The following is a description of a gene set: Abnormal umbilicus morphology studied in species Homo sapiens An abnormality of the structure or appearance of the umbilicus. Human Gene Set: HP_ABNORMAL_UMBILICUS_MORPHOLOGY, and this is the list of marker genes: HSPG2, ANTXR1, FRAS1, IRF6, EIF4H, FTO, MBTPS2 (NCBI Gene Id 51360), ZMPSTE24, MYH3, ROR2, MID1, LMOD1, HESX1, FKBP14 (NCBI Gene Id 55033), POLR3GL, SCN2A, EHMT1, GPC4 (glypican 4), ERCC3, FANCL, MLXIPL, TARS1 (NCBI Gene Id 94887), NOTCH1, TFE3 (transcription factor binding to IGHM enhancer 3), FZD2, NSD1, FANCA, PHGDH, PNKP, UFD1, KNSTRN, GTF2IRD2, SLC2A10, LHX4, AGPAT2, SLC5A5, PORCN, NAA10, SLC32A1 (solute carrier family 32 member 1), ABCC8, TRIP11, FANCE, PRDM5, TRPV6, LRP2, NEUROD2, GTF2IRD1, AUTS2, GZF1, TOR1A, BRIP1, NKX2-1, NOTCH2, AARS1, EZH2, COL5A1, SLC25A22, RFC2, TGFBR2, CAVIN1, PLAGL1, FANCM, FREM2, DMXL2, PRR12, CHRNG, C1R, EFNB1, KMT2C, SRCAP, IDUA, FANCD2, LBR, GPHN, FBLN5, CLIP2, NFIX, MEG3, GJA1, DVL1, BSCL2, MYLK, FOCAD, PIK3CD (NCBI Gene Id 5293), ATP6V0A2 (ATPase H+ transporting V0 subunit a2), MSX1, GMNN, BUD23, ATAD1, RREB1, RFWD3, DNMT3A, MED13L, STX1A, CDKL5, KCNJ11, ACTG2, KCNA1, EOGT (NCBI Gene Id 79580), MED12, KRT1, LONP1 (lon peptidase 1, mitochondrial), ADAMTS2, ARVCF, GRM7, SH3PXD2B, ERCC2, GRIP1, RNF113A, GPC6, NXN, SLC26A2, SGSH, MYH11, CAPRIN1, SLC25A24, FGD1, NSDHL, KIF7, ADNP, PIGL, ELN, RAB23, HYMAI, GUSB, ARX, MESP2, ZBTB24, MAPRE2, DUOX2, GLI3, LTBP4, BCL11B, MAN2B1, DGCR8, MTOR, SLC35C1, DLL3, IYD, COX11, SUZ12, TP63, NKX2-5, SIK1, METTL27, RTL1, GRIN1, GTF2I, GATA6, SALL1, BAZ1B, PIGQ, PPP2CA, TBX1 (T-box transcription factor 1), FANCB, SPECC1L, CLDN19, DNMT3B, ATRX, KCNH1, CDCA7, OCLN, FOXE1, ABCC9, APC2, SLC6A5, SNIP1, ISL1, PTCH1, HIVEP2, B3GLCT, DNAJC30, PPIB, SCN1B, UHRF1, COL1A1, COL5A2, RNF2, LFNG, TUBB, DLK1, BRCA2, TWIST2, DVL3, SOX6, ERCC4, SLX4, AEBP1, BGN, IDS, RIPK4, FANCI, CHAMP1, MPLKIP, NOTCH3, GPC3, HIRA, GNAO1, RFX7, TSHR, PAX8, IPO8, KAT6A, GLIS3, IFT140, KCNJ8, ZBTB7A, MASP1, TG, ARSB, PIGS, COLEC10, DUOXA2, CHD3, LHX3, HDAC4, NEU1 (NCBI Gene Id 4758), FBXW11, SEC24C, SEMA3E, TBL2, GTF2H5, COL3A1, FBN1, SKI, RAC1, CDH11, CSNK2A1, DEPDC5, SMARCA2, NECTIN1, BMP1, FKBP6, WNT5A, ALDH18A1, ATP7A, MEGF8 (NCBI Gene Id 90198), EED, TPO, CCBE1, FBXL4, PRKG2, H4C3, PACS1, HELLS, PIGP, SMARCB1 (NCBI Gene Id 6598), SMAD3, H19, RAP1B, FANCG, CARS1, PROP1, CHST14, LIMK1, ELMO2, JMJD1C, GLRA1, TRIM8, DICER1, AGA, RIPPLY2, TRRAP (transformation/transcription domain associated protein), TRAF7, C1S, PLOD1, TMEM70, COMT, RIN2, IKBKG, RAD51, ESS2, ACTB, ZFX, SLC26A4, NALCN (sodium leak channel, non-selective), SEC31A, VPS37D, ZFP57, RNU4-2, GTF2E2, PALB2, UBE2T, TSHB, DGCR6, FANCC, MAD2L2, LMNA (NCBI Gene Id 7816), FGFR2, CHD7, CREBBP, DGCR2, FANCF, CASK, GP1BB, SETBP1, HES7, COLEC11, TMEM270, TGDS, GNPTAB, POU1F1 (NCBI Gene Id 5449), BRCA1, SLC35D1, OCRL, RAD51C, IGF2, KDM3B, BCOR, TENT5A (NCBI Gene Id 55603), XRCC2, NCF1, FLNA (NCBI Gene Id 8272), SMAD2, PIGW, GLRB, ARID1B, POGZ (pogo transposable element derived with ZNF domain), COL2A1, EN1